Given this list of marker genes RNF38, TRAF3, GID4, TMPRSS3 (NCBI Gene Id 93657), NEXMIF, KCNK13, PPFIA1, ILDR2, PPP3CA, ZNF584, HOXA9, TAFA2, ZNF367, NUDT13, COL4A1, ZNF205, NAA30, BHLHE40, SNAP47, MON1B, ARHGAP35 (Rho GTPase activating protein 35), ARF6, CCDC85C, SEC14L2, ZNF586, CASK, SPOPL, PILRA, SLC17A5, INSYN2A, IL17B, CDC14A, ITGB1BP1, SLC24A2 (NCBI Gene Id 25769), ZNF781, CERT1, KLHL29, ZNF780B, ADRA2A, MED13L, PIP5K1B, DERL2, MSANTD3, ZNF74, SCG2, DYNLT3, NMNAT1, DENND6A, SPARC (secreted protein acidic and cysteine rich), BZW1, ZNF773, GRID2, SEH1L, MAP2, ABHD17B, NUP58, DENND11, here is a description of the gene set: from publication Chen Y, Wang X (PMID 31504780) species: Homo sapiens Human Gene Set: MIR3142 Genes predicted to be targets of miRBase v22 microRNA hsa-miR-3142 in miRDB v6.0 with MirTarget v4 prediction scores > 80 (high confidence targets).